The following is a description of a gene set: Genes up-regulated in CD4 T cells with STAT3 knockout: TGF beta versus IL6. from publication Durant L, Watford WT, Ramos HL, Laurence A, Vahedi G, Wei L, Takahashi H, Sun HW, Kanno Y, Powrie F, O'Shea JJ (PMID 20493732) species: Homo sapiens STAT3, an essential transcription factor with pleiotropic functions, plays critical roles in the pathogenesis of autoimmunity. Despite recent data linking STAT3 with inflammatory bowel disease, exactly how it contributes to chronic intestinal inflammation is not known. Using a T cell transfer model of colitis we found that STAT3 expression in T cells was essential for the induction of both colitis and systemic inflammation. STAT3 was critical in modulating the balance of T helper 17 (Th17) and regulatory T (Treg) cells, as well as in promoting CD4+ T cell proliferation. We used chromatin immunoprecipitation and massive parallel sequencing (ChIP-Seq) to define the genome-wide targets of STAT3 in CD4+ T cells. We found that STAT3 bound to multiple genes involved in Th17 cell differentiation, cell activation, proliferation and survival, regulating both expression and epigenetic modifications. Thus, STAT3 orchestrates multiple critical aspects of T cell function in inflammation and homeostasis. Human Gene Set: GSE21670_TGFB_VS_IL6_TREATED_STAT3_KO_CD4_TCELL_UP, and this is the list of marker genes: MAP9, UTP14A, KDM5B (NCBI Gene Id 10765), TIAM2, DYRK2 (dual specificity tyrosine phosphorylation regulated kinase 2), TNFRSF1A, GRIN3B, WIPF2, AMMECR1L, NHLRC3, CCM2, AMER1, CMTR2, TFB2M, TMOD2, ITPRIP, CDH1, GCK, NPC2, MTAP, MRGBP, TSPYL4 (TSPY like 4), CRTC3, P4HA1, JAG2, ZFAND5, VANGL2, KRBA1, CRIM1, PLCE1, ISLR2, RUFY2, LRRC75B, TPRG1L, KCTD21, XKRX, LRIG1, LHFPL6, UTP20, DEPP1, AQP2, SLC44A3, CMTM6, IGLON5, BMPR1A, SEMA4B, ITGAE, GPR39, ZNF652, TMEM88, DZIP1, TSC1 (NCBI Gene Id 7248), CREBL2, PHF3, TLR7, GBP7, IDNK, FNDC1, RPH3AL, GPATCH3, SEPTIN8, UVSSA, KCNK2, PTTG1IP, TRMT1, BLOC1S6, GALNT11, BEND4 (BEN domain containing 4), RPLP2, MYLIP, THADA, EPHX1, METTL8, USP18, PUM1, ACADSB, MAN2A2, VSNL1, FAM91A1, RGS11, MAN2C1, RWDD3, DDI2, SH3PXD2A, KIAA0040, NDUFAF4, HECTD4, ZBTB18, FGFBP3, DCAF11, SLC25A28, NEDD9, SGK3, TGFBI, OAS2, RSPH4A, F2RL1, TIMM10, DPH6, FBN2, RALGPS2, ACP5, MCC, SLFN13, DBNDD2, FASTK, AP1AR, ZBTB8A, NELFA, SYT10, EEF1G, LRP6, ZNF287, TRIO, CIMIP1, EME2, NLK, SCTR, BCL6B, MMP14, DLGAP2, CCND2, PCDHAC1, BCL2, TREML2, CTSS, CSRNP2, PRDM2, SLC22A17, PDE11A, ERCC5, PDE3B (phosphodiesterase 3B), MIGA2, SOS1, RGMB, CCDC126, SMPD5, LTB, RNASET2, DSTYK, NR1D1, RAMP1, RAB20, AGO2, ZNF623, RPL13, C9, TSPAN9, KRI1, VIPR1, MCFD2, SPRYD4, NALCN, MAT2A, MAP3K3, TSC22D1, RGCC, MRM1, BCAR1, ZNF639, BRD2, STIMATE, RAB40C, LRTM2, ZSCAN5B (NCBI Gene Id 342933), ZNF281, POMGNT1, SMIM14 (small integral membrane protein 14), RREB1, DENND1A, IMPACT, CNNM3, RNF2, PDE2A, PPRC1, HBP1, CTSW, CDC14B, CHD9, TSACC, ZC3H6, CDH16, PHF20, ETV3, KCTD12, CALHM6, SELENBP1, SMURF2, SLC38A2, GADD45G, STON1, RPS8, ZNF354C, RPS19, MAP3K12, ZBTB9, PARD6G (NCBI Gene Id 84552), LETM2, TMEM86B